Given this list of marker genes MYO1F, SECTM1, ADCYAP1R1, FOLR2, SH3YL1, SLC7A1, DGAT1, AASS, GDF15, PRRX1, ARR3, MUC6, ALAS1, ITGAL, GBP1, SCN9A, NUDT1, RALY, BTRC, RBL1, NR5A2, BST2, HPCAL1, NDUFS3, SOD1, TNFRSF14, EIF3K, PPFIBP2, C1QB, IMPDH1, CORO1A, TP53I11, STARD3, IRF1, DHX38, SPARC (secreted protein acidic and cysteine rich), NDST2, UBA1, BCKDHA, MRPL28, HLA-DPA1, RIMS2, FXR2, DEDD, MRPL23, CTSA, UBAP2L, H2AZ1, SIPA1, CYBA, PHGDH, ZFHX3, RNH1, ELAVL4, SPG7, VPS52, MGMT, XPO6, TTC39A, CLCN6, NCOR2, AIFM1 (NCBI Gene Id 9131), CPVL, RPL13P5, SLN, KPNA2, TNK2, PYGM, BUD31, SF3B2, GAA, IQSEC2, TIMP2, TMEM268, SREBF2, CCL5, IFITM3, HLA-DMA, ACTN1, ANGEL2, CD27, OGDH, SRRD, GNA15, ADA, FCN1, MGRN1, PC, SRPX2, LILRA2, PRKAG1, TEX28, DHX16, PRPF8, CNR1, CNPY3, DNAJB2, AIMP2, LRRC8B, CAP1, SAC3D1, VGLL4, PLTP, PBX2, STAB1 (stabilin 1), OVOL3, PSMB4, PSMB6 (NCBI Gene Id 95505), RPL12, RASSF2, PLCG2, TRAPPC6A, DIAPH1, SMPD1 (sphingomyelin phosphodiesterase 1), DAP, SEC13, TTF1, EIF3H, SH3BP1, NIT1, NDUFS7, MX1, SGSM3, PLXND1, LGALS9, INTS9, PSMB8, EPHX1, PCK2, VCAM1, OAS1, RHOBTB2, SGTA, REM1, AKR1B1, NMI, SULF1, RPA3, TAF10, SNED1, DLEC1, AMHR2, C6orf47, PTPRCAP, CAPNS1, SUSD6, FCGBP, POU3F4, HEXA (NCBI Gene Id 3073), UBA7, KMT2A, CROT, ATP5MF, CD37, HLA-DMB, AP1B1, SNX27, CD302, ADGRE1, ALDH3A2, NCF4, FADD, FUCA1, TAP1, CNPY2, TRAFD1, PXDC1, KCNJ9, MAFF, SNX1, SF3B4, EHD1, GTPBP1, IDH3B, IRF7, LMO2, ATP6V0A1, DOCK2, IGFBP4, EEF1B2, ZBTB24, PRKCD, GAK, TXN2 (thioredoxin 2), TNFSF10, DUSP3, HSD17B3, IFFO1, VAV1, TIMM44, TNFAIP6, STAT6, AOAH, INPP5B, ACADS, PPM1G, NUFIP1, URM1 (NCBI Gene Id 81605), CHST1 (carbohydrate sulfotransferase 1), H1-10, here is a description of the gene set: species: Homo sapiens Monocyte-derived dendritic cells (DC) and macrophages (MΦ) generated in vitro from the same individual blood donors were exposed to five different pathogens, and gene expression profiles were assessed by microarray analysis. Responses to Mycobacterium tuberculosis and to phylogenetically distinct protozoan (Leishmania major, L. donovani, Toxoplasma gondii) and helminth (Brugia malayi) parasites were examined, each of which produces chronic infections in humans yet vary considerably in the nature of the immune responses they trigger. Human Gene Set: GSE360_L_DONOVANI_VS_B_MALAYI_HIGH_DOSE_MAC_DN from publication Chaussabel D, Semnani RT, McDowell MA, Sacks D, Sher A, Nutman TB (PMID 12663451) Genes down-regulated in comparison of macrophages exposed to L. donovani versus macrophages exposed to 50 worms/well B. malayi.